The following is a description of a gene set: Mouse Gene Set: GOBP_RESPIRATORY_CHAIN_COMPLEX_IV_ASSEMBLY The aggregation, arrangement and bonding together of a set of components to form respiratory chain complex IV (also known as cytochrome c oxidase), the terminal member of the respiratory chain of the mitochondrion and some aerobic bacteria. Cytochrome c oxidases are multi-subunit enzymes containing from 13 subunits in the mammalian mitochondrial form to 3-4 subunits in the bacterial forms. studied in species Mus musculus, and this is the list of marker genes: Cox14, Cox17, Cox18, Sco2, Slc25a46, Cox19, Cox16, Tmem223, Fastkd3, Bcs1l, Coa7 (cytochrome c oxidase assembly factor 7), Cep89, Pet117, Smim20, Uqcc6, Coa5, Coa4, Cox10, Cox20, Surf1, Coa6, Coa8, Timm21, Sco1, Coa3, Stmp1, Uqcc5, Pet100, mt-Co3, Taco1